The following is a description of a gene set: from publication Amit I, Garber M, Chevrier N, Leite AP, Donner Y, Eisenhaure T, Guttman M, Grenier JK, Li W, Zuk O, Schubert LA, Birditt B, Shay T, Goren A, Zhang X, Smith Z, Deering R, McDonald RC, Cabili M, Bernstein BE, Rinn JL, Meissner A, Root DE, Hacohen N, Regev A (PMID 19729616) mouse primary BMDCs were stimulated with tlr ligands and gene expression changes were profiled on Affymetrix arrays Human Gene Set: GSE17721_12H_VS_24H_LPS_BMDC_UP studied in species Homo sapiens Genes up-regulated in comparison of dendritic cells (DC) stimulated with LPS (TLR4 agonist) at 12 h versus those stimulated at 24 h., and this is the list of marker genes: ITSN2, FEZ2, RHBDF1, NR1H3, RGS14, DNAJB13, DENND6A, IER5, ARID1A, CLDN19, SOCS1 (NCBI Gene Id 8651), CRYGS, PLEC, PARP8, EEF2K, SPATA4, CA13, ISG15, IGBP1, SH3BP2, TSPAN33, NXF1, SLC9A8, FCGR3A, SOX12, PAX1, IFIT3 (interferon induced protein with tetratricopeptide repeats 3), NUP93, TMOD3, P2RY6, CAMKK2, KIF1C, CCL24, KLF10, ARNT2, PPP2R2A, MORC3, NEK7, MED21, SERPINB6, IRF4, TGFBR1, PRPF38A, PTPRC, BIRC3, IL21R, CCNG2, ITGAV, PLXDC2, CCL22, OAF, IL6, ZC3H12C, NRROS, S100A11, OAS2, AEBP2, ANXA2, SLC3A2, SLC15A5, GRK6, NCOA3, CLRN3, DUSP9, BNIP2, KLK6, KCNN4, CREB3, ECE1, KLF6, ITSN1, VRK2, PSME1, MAPRE2, PCLAF, ITGA3, RAB11A, RFFL, SLC7A8, CTTN, TMEM268, SH3TC1 (SH3 domain and tetratricopeptide repeats 1), CHMP2A, RBMS1, YWHAH, TNFSF8, CFP, SPRYD7, SCHIP1, KATNA1, TBC1D8, DAXX, WRNIP1, OVOL1, ZYX, NFKBIA, MYD88, SMC4, MCUB, ASTN1, CHMP4B, FLII, CORO2A, DNAAF1, AKR1D1 (NCBI Gene Id 6718), HDAC7, ATF3, PARP12, NDRG1, SIAH2, INPP1, SGK3, CLTA, KDR, TOR3A, RSPRY1, CAPN2, FNDC3A, SLC22A5, STAG2, GPR84, BATF3, GBP6, IKZF4, BICC1, SPSB1, PXK, LRRC4, TMEM132A, ELAC1, RASA2, ADAMTSL5, CMTM3, VPS37C, PPAN, DNAJB11, RPS6KA2, RAB12, PRRC1, SLC28A2, RABL3, KCNAB1, PDLIM5, GRM8, RNF114, CCNL1, DIAPH1, WNK1, WDR1, NIBAN2, RHO, ADORA2B, ITGA4, RAP1B, TLR6, DCBLD2, PLEK, IQGAP2, KBTBD2, MKNK1, PCSK7, SRSF9, ARHGEF2, LTA, CLK3, PENK, KCTD14, MAP3K11, RCN1, MESP2, PLAAT3, RRH, ABCG2, SLIT2, IFFO2, FN1, TNFRSF11A, SSX5 (SSX family member 5), SAV1 (salvador family WW domain containing protein 1), ALDH1B1, REEP3, EHD4, GPR85, NAB2, CASP4 (NCBI Gene Id 837), CNPPD1, IRF1, UBE2E2, USB1, PRKG2, FYCO1, JAG1, MDFIC, PLGRKT, APLP2, FGR, PSMD8, TNFAIP2, FAM3B, FKBP15